Given this list of marker genes CYBRD1, RBM24, EPHA3, TAX1BP3, SCN11A, PRKCQ-AS1, GEMIN4, MRS2, ATP5F1A, OIP5, PPP1R2, GMEB1, SLC25A33, GIPC2, TUBE1 (NCBI Gene Id 51175), LRRC23, ZNF607, PAEP (progestagen associated endometrial protein), CTNND2, FRZB, PAG1, ENPP4, AIG1, APTX, TMEM51-AS1, STIMATE, UPP1, CFHR2, PPTC7, RGCC, PSMB4, CLEC4E, SLC25A32, CCNA2, CENPBD1P, ZNF775, RFPL2, NMU (neuromedin U), THAP12, CHMP2B, FABP3, TMEM87B, MTMR12, RNFT1, MTFR1L, MTMR10, ZBTB17, CSF1R, SCN10A, ARHGAP1, MECOM, NICOL1, FOXL2, USP27X-DT, GUSBP2, KRT20, LATS1, CA13, PRSS16 (serine protease 16), SCAF8, FAHD1, SMPDL3A, TRPC5OS, ZRANB1, PRORSD1P, KBTBD8, ADD2, GSTM5, NUS1P3, SPTLC1, GOLT1B (NCBI Gene Id 51026), GIP, HNRNPLL, CDK5R2, BTG4, EBNA1BP2, ADAM17, HOXB7, SUMF2, ATP6V1G2 (ATPase H+ transporting V1 subunit G2), CHST9, NALF1, ATOH8, LNPK, BASP1-AS1, CROT, CHN1, FASTKD3, USP3-AS1, SGO2, HESX1, SDE2, STAM, ZMYM1, CENPM, TMEM106B, NEK2, BTK, ADAMTSL5, TADA2A, PPP1CC, CGRRF1, HSF2, OR2L1P, NMT2, NDFIP2, TMEM177, GUSBP1, SOAT1, FAM217B, CCT8, TDO2, DUSP8, BBS10, GPX8, GCH1, SLC22A18, ZNF492, TIMM17A (NCBI Gene Id 10440), CXCL11 (NCBI Gene Id 6373), CLDND1, GFOD1 (NCBI Gene Id 96191), TMED7, HCFC2 (host cell factor C2), RALA, FMO1, CATSPER1, PPIL4, HERC2, AKAP4, COQ4, PHLDA1, GEN1, ZNF354A, CASD1, MRPL9, MELK, FBXL13, SNAP25, BTC, RXFP1, CRY1, SYS1, GPR37 (G protein-coupled receptor 37), STPG2, NUDT18, B3GLCT, PLAA, SLC4A1AP, PAQR3, CLDN1, ANXA5, NRIP3, GSPT2, NAGS, BAALC, TWF1, TIFA, CT45A5 (cancer/testis antigen family 45 member A5), C12orf50, PIGB, VPS50, ST6GAL1, UMPS, VDR, CRLS1, OSBPL11, IGKV4-1, YIPF4, MSRA, GALNT1, DPY19L3-DT, KATNA1, ALDH18A1, POLR1HASP, GIMAP4, PROP1, MANEA, CEBPZ, GDPD1, TMTC1, HOXA10, MCPH1-AS1, GMFB, CLDN12, PPP1R26-AS1, KLRA1P, ARL4D, GALNT12, PTGES3, MAP2K3, NRIP2, CIPC, HOXA5, here is a description of the gene set: Human Gene Set: GSE45365_NK_CELL_VS_CD8A_DC_MCMV_INFECTION_DN studied in species Homo sapiens Genes down-regulated during primary acute viral infection: NK cells versus CD8A dendritic cells. Murine Cytomegalovirus (MCMV) infection leads to early activation of various immune cells, including B and T lymphocytes, before the actual initiation of antigen-specific adaptive immunity. This activation is partly driven by innate cytokines, including type I interferon (IFN), which are induced early after infection. The objective of this study was to address the role of type I IFN in shaping early/innate B and T cell responses to a primary acute viral infection. In order to decipher the specific impact of IFN-I on cell subsets, we performed a genome-wide expression analysis on WT splenic B and CD8 T lymphocytes isolated from C57BL/6 mixed bone marrow chimera mice. This study complements series GSE39555, which focused on early responses of NK cells and of the two subsets of conventional dendritic cells.